Given this list of marker genes PRKAA1, NACA, BCL2, SHH, MRTFB, DCANP1, YBX3, ERBB3, CTNNB1, SMAD3, FLOT1, CENPF (centromere protein F), LEF1, MYOG, LOX, BMP4, SOX15, ACTN3 (actinin alpha 3), TWIST1, MEF2C, MYF5, WNT10B, FGF8, LUC7L, SHOX2, CREB1, WNT3A, JPH2, USP19, TGFB1, SIRT2, TIFAB, RPL3L, CDON, MTPN (NCBI Gene Id 94351), DLL1, MEGF10, IGF2, SFMBT1, MYOD1, FGF3 (NCBI Gene Id 2248), MYF6, MTM1, NEUROG1, LMOD3, here is a description of the gene set: Any process that modulates the frequency, rate or extent of muscle development. studied in species Homo sapiens Human Gene Set: GOBP_REGULATION_OF_MUSCLE_ORGAN_DEVELOPMENT